Given this list of marker genes ATP5MC2, MAP2K6, PSMB9, ZBTB10, NT5C3A, HTR5A, BMP5, LRMDA, ERG, LRRTM4, SHFL, BCL6 (BCL6 transcription repressor), SLITRK2, FAM50A, CYTH3, RAPH1 (Ras association (RalGDS/AF-6) and pleckstrin homology domains 1), PDE4D, USP2, MAP2K5, KPNA3, COL11A2, TASL, CFL1P1, ESR1, CHST8, TMBIM4, SST, IFIT2, SLC12A7, APOBEC2, LOX, LAPTM4A, RUNX1T1, NOS1, EYA1 (NCBI Gene Id 2138), CMTR1, MOV10, TRPM3, OSM (oncostatin M), STX16, ACSBG1, ISG15, SOX5, LRP6, YTHDF2, NR4A3, CELF4 (NCBI Gene Id 56853), TMEM115, KIRREL3, TAPBP, CXCR4, PITX2, SLC4A10, DMD, ERBB2 (NCBI Gene Id 2064), ELAVL2, FEV, KIRREL3-AS3, PNKD (PNKD metallo-beta-lactamase domain containing), LRATD2, WASHC4, TUBD1, LIX1, MOSMO, ARF6, CACNA1A, CCDC6, TLK2, BNC2, EGR4, ANGPTL4, TREX2, JPH4, HMGB3, LHX6, RAPGEF6, KDM3A, IFNB1 (interferon beta 1), IRF2, ZNF516-DT, ZDHHC14, LZIC, PIK3CD, PSME1, E2F3, LSM6, GPX1, SOCS1, SAT1, ZMYND8, DDX60, AGPAT4, GATA6, HIVEP1, DLX4, BST2, ITGB7, INTS9, HOXD13, DPCD, USP18, ZFP36L1, MSX1, MXD3, UBR4, MIR137HG, LDB2, ALKBH6, ECEL1, GRM7, AMY2A, MSANTD2, CACNA2D3, HOXB3, SOX4, CUL2, FLI1, SIPA1L1, UPF2, OASL, TENT4B, PPP2R2A, TAP1, EGFL6, PLEK2, ARRDC3, CALD1, HOXC10, RBFOX1, SLC25A28, PARP12, UBA7, METTL26, RFX4, NOVA2, CASZ1, PARP8, CDYL, CBX4, ARMCX6, TRIM21, PABPC4, PARP9, PSMA3, FLRT2 (fibronectin leucine rich transmembrane protein 2), LIF, HOXB8, ZNF362 (NCBI Gene Id 170467), LGALS3BP, FIBCD1, TCF12, SRPX2, HS6ST2, HHATL, ABI3, RBCK1, AZI2, DLEU1, MPL, PDE1B, EN1, PKN2, CD40LG, IL18BP, TIA1, CASP7, PCGF5, ELK4, XAF1, VIT, SCUBE3, EPHA7, PPP1R10, RIGI, IL27, RFX5, POLL, AAMP, PKN3, ZHX2 (zinc fingers and homeoboxes 2), TSC1, SALL3, TAF5, GNGT2, RASGEF1A, DAPP1, ZMYND15, LYPD6, ARTN, PDGFC, COMMD10, DLL4, LINC00173, EVL, STX11, SP110, NABP2, GPR162, EPSTI1, COL12A1, RDH10, BATF2, POPDC2, LHX5, TCF15, FAM110D, MAP3K8, CXCL10 (NCBI Gene Id 3627), PRDM16, ABHD16A, GDI1, IL22RA1, DLX1, NFIX, FOXP2, SECISBP2L, PRDM13, RBL1, OPTN, GDNF, HOXA10, CCL3, TNFSF15, MRPS18B (mitochondrial ribosomal protein S18B), FHL3, EXOC6, CPT1A, DDX17, GSC, DICER1, LHX9, PLXNC1, PHLPP1, SEPTIN9, NMNAT1, ADAR, FOS, NR4A2, GNA13, TMEM229B, NRP1, RFX3, CHMP3, PTMS, IL4, CXCL16, DLEU2, KIF13A, DTX3L, NPR3, PCBP1, RPS6KB1, HMBOX1, NOG, TLX2, GRM3, SOBP, GJC1, here is a description of the gene set: species: Homo sapiens Genes having at least one occurrence of the motif TNSGAAWNCGAAANTNNN in the regions spanning 4 kb centered on their transcription starting sites. This matches the IRF7 transcription factor binding site V$IRF7_01 (v7.4 TRANSFAC). Human Gene Set: IRF7_01